The following is a description of a gene set: species: Mus musculus Mouse Gene Set: GOBP_REGULATION_OF_CD8_POSITIVE_ALPHA_BETA_T_CELL_ACTIVATION Any process that modulates the frequency, rate or extent of CD8-positive, alpha-beta T cell activation., and this is the list of marker genes: Hfe (homeostatic iron regulator), Crtam, Cd244a, Zbtb7b, Irf1, Mapk8ip1, Ptpn22, Cbfb, Lilrb4b, Xcl1, H2-T23, Slc4a2 (NCBI Gene Id 20535), Cd274, Lilrb4a, Vsir, Runx1, Dapl1, Nckap1l, Sh3rf1, Socs1, Runx3 (NCBI Gene Id 56483)